The following is a description of a gene set: A cellular senescence process associated with the dismantling of a cell as a response to oncogenic stress, such as the activation of the Ras oncogenic family. studied in species Homo sapiens Human Gene Set: GOBP_ONCOGENE_INDUCED_CELL_SENESCENCE, and this is the list of marker genes: PML, HMGA2, CDKN2A, HRAS (HRas proto-oncogene, GTPase), CDKN1A, HMGA1, SPI1